The following is a description of a gene set: species: Homo sapiens Human Gene Set: MODULE_213 NCI cell lines expression clusters., and this is the list of marker genes: HMGA2, EFNA1, CHI3L2, ACR, CHGA, DGCR2, PFKFB4, ADARB1, SLC11A2, NAB2, APBA2, EDC4, CCNF, LAPTM5, AIF1, AZGP1, SHMT1, CFD, TYR, TSPAN8, KRT5, ID2, CD2, DNTT, RAB11B, GPX2, SOX4 (NCBI Gene Id 6659), SEPTIN6, TMSB15A, PIM2 (Pim-2 proto-oncogene, serine/threonine kinase), CXCR4, GPNMB, PLA2G2A, JUNB, NKG7, HLA-DMA, KCNQ2, CEACAM1, TFF3, ID4, UCP2, SLC2A3, IL2RG, TYRP1, ELN, APOE, SELENBP1, DCAF7, ALDH3A1, AGXT, RAD9A, NRG1, MAN2A2, GRIN1, ABCA3 (NCBI Gene Id 21), SLC25A1, PTPN3, TFF1, P2RX1, DGKA, KMT2A, IFI30, PTPRC, PTPRN2, MLC1, DPEP1, NNAT (NCBI Gene Id 4826), PTPN7, ADIRF, RAC2, WFDC2, FXYD3, GNG4, PRKCQ, NTSR1, ICAM3, TOB1, TRIM29, EPHX1, SOD3